Given this list of marker genes MXI1, ANKRD36, DSC2 (desmocollin 2), SDS, HLA-DPA1, COBLL1, SYNGR4, ZMIZ2, APOC1, CTSF, CFP, KLHL21, ALDH5A1, HSD17B11, MDM2, CEP350, PELI2, CLIP4, ABCC5, VWF, CREBL2, CBX5, MST1, FZD2, PER3, CEBPD, NUPR1, STAG3 (NCBI Gene Id 10734), CST3, SRSF5, PIGT, ZBTB40, AHR, AMZ2, ZNF274, WDR48, BTBD18, CPVL, HLA-G, ZNF589, LGR4, MMP7, P2RX7, MACROH2A1, RNASE6, PLA2G4C, APBA3, GADD45G, DHRS9, MECP2, ACP5, MAP3K12, HLA-DRB6, APOE, DPEP2, HBP1, FGD2, HLA-B, GUSB, FOXO3, LRCH3, KLKB1, HLA-F, TRIM33 (tripartite motif containing 33), PDGFC, HLA-DPB1, CNNM4, CYBRD1, PIP, BCAR3 (BCAR3 adaptor protein, NSP family member), MLN, AOAH, NENF, CDKN1C, NAAA, DDC, TAX1BP1, SLC29A3, ACSM5, ZZEF1, SLC29A1, SEMA4A, BTN3A3 (butyrophilin subfamily 3 member A3), RGS2, IQCK, EPHX1, CTSS, PTPRH, TOP3A, NOTCH2, ORAI3, SMPDL3A, NREP, RRN3P1, POLL, GTF2IRD1, SLC7A11 (NCBI Gene Id 23657), CBX7, HLA-E, HTR2B, CTSD, FABP4, RNF146, KCTD7, HLA-DMA, ADA2, DNASE2, RPS14, AKR1B1, LYZ, CCNG2, FLI1, TLR8, CFD, DHRS3, CRY2, ISCU, DAPP1, EPB41L1, RAB20, SAMD4A, CD81, SDC3, PI4K2A, CXCR4, SCARB1, BRD3, TTLL4, SERPINF1, OGT, SCAMP1, LTBP3, CCL21, CLIC2, MYLIP, HLA-DMB, IRS2, HLA-DQA1, ABR, MARCHF8 (NCBI Gene Id 220972), IL10RA, CXCL12, STK24, CYP27A1, KCNMA1, DTNB, CLEC10A, SERPING1, CALCOCO1, CA11, SIDT1, RNASET2, TNFAIP2, TCF4, SAT1, CD86, BHLHE41, TMEM268, MITF, ITGAX, TPT1, PCGF3, ZNF688, PITPNB, MAP3K5, HLA-DQB1, SLC35E2B, DNAJB2 (NCBI Gene Id 3300), HLA-DRB1, SPARC, NR1H3, DYRK2, KLHL24, NINL, EPB41L2, CAMLG, MEPCE (methylphosphate capping enzyme), SLC46A3, NOTCH2NLA, PABPC4, MAU2 (NCBI Gene Id 23383), TLR5, HYI, POU6F1, HLA-DRA, PLEKHA2, DBP, PLA2G2F, CHRM5, LRRC8D, CLEC2B, SNHG32, KCNJ5 (NCBI Gene Id 3762, potassium inwardly rectifying channel subfamily J member 5), PIK3CD, DNAJC22, ABCG1, PRG2, here is a description of the gene set: from publication Cho JS, Guo Y, Ramos RI, Hebroni F, Plaisier SB, Xuan C, Granick JL, Matsushima H, Takashima A, Iwakura Y, Cheung AL, Cheng G, Lee DJ, Simon SI, Miller LS (PMID 23209417) Genes up-regulated in skin: wildtype versus IL1R1 knockout. Neutrophil abscess formation is critical in innate immunity against many pathogens. Here, the mechanism of neutrophil abscess formation was investigated using a mouse model of Staphylococcus aureus cutaneous infection. Gene expression analysis of S. aureus-infected skin revealed that induction of neutrophil recruitment genes was largely dependent upon IL-1beta/IL-1R activation. Unexpectedly, using IL 1beta reporter mice, neutrophils were identified as the primary source of IL-1beta at the site of infection. Furthermore, IL-1beta-producing neutrophils were necessary and sufficient for abscess formation and bacterial clearance. S. aureus-induced IL 1beta production by neutrophils required TLR2, NOD2, FPRs and the ASC/NLRP3 inflammasome. Taken together, IL-1beta and neutrophil abscess formation during an infection are functionally, spatially and temporally linked as a consequence of direct IL-1beta production by neutrophils. Human Gene Set: GSE36826_WT_VS_IL1R_KO_SKIN_UP species: Homo sapiens